Given this list of marker genes RHOB, MAP2K2, EMC1, RMDN3, ANAPC2, DUSP19, RALBP1, CCT8L2, PSMD9, SHISA2, FAM20A, SLC35D1, PPFIBP2, TARS2, KCNH2, NME6 (NME/NM23 nucleoside diphosphate kinase 6), ANAPC16, RPTOR, GPR61, PRAP1, CPQ, CENPH, NRDE2, EIF2B4 (eukaryotic translation initiation factor 2B subunit delta), ETFDH, VDAC3, ELMO3, SREBF2, GFM1, TMEM273 (transmembrane protein 273), AAMDC, RABGAP1L, ARL4A, ARL5B, ZNF7, PLEKHH1, VSIG10L, RTCB, MESD, OAS1, MAP1S, PLG, BORA, MYPN, NCCRP1, PIF1, RCBTB1, CHMP4B, TRIQK, MFSD12, TOPBP1, MSL2, MRPL2, TLL2, RNF40, MMP11, RACK1, FRS2, YTHDF1, DRP2, SEPTIN9, CCT4, STAB1, TXN2, NELFCD, ATP5F1D, CHTF8, RBL1, MRPL36, ERRFI1, DGCR8, CTDNEP1, ALDH1L2, CBX6, RARG, RBMXL2, CLDN7, C22orf23, LAS1L, SWI5, POLR2H, C6orf132, NOB1, BUD31, PDHA2, REEP4, NUP50, TPPP, B9D2, NSUN5, ENTPD6, WBP11, OPN1SW, TRIM29, PGBD5, DRG1, MDC1, PSD, CDKN1A, GLRX5, TOMM7, ZNF175, UBXN11, WDR3, TNIP1, PHACTR4, MAPK1, CERS6, CHPF, OPN1LW, EGR3, ESAM, IL12RB1, IBA57, TAPT1, ARHGEF4, DAPL1, TRIM35, CCDC88B, GCHFR, ZC3H7B, KCNK5, ANKRD54, RXRA (NCBI Gene Id 6256), PCBD2, TRAF2, CPTP, CD109, BOD1, TAF4B (NCBI Gene Id 6875), PSMD12, ANGPTL4, SLC9A5, RPS3, EVPL, SPRED1, GATA1, INTS9, EXOSC1, RNF24, NOL11, PIP5K1B, PPIP5K1, TKFC, ECSIT, CERS5, TRUB1, TANGO6, COPS5, COX19, C11orf87, PLD4, MECR, MFSD2A, SLC6A4, MYO1H, B4GALT4, PEF1, ADH4, MARCO, ZNF483, STAT1, RBM11, CAPN10, SP7, CRYL1, SLC35A4, BCL6B, PPP1R7, TCEAL8, RBBP5, GLOD4, GARIN1B, DHX32, PPM1B, B3GNT7, HJURP, SYNDIG1L, NEUROD2 (neuronal differentiation 2), MIS12, DNAJC24, MRPL46 (NCBI Gene Id 64128), LONP1, SCFD2, PGAM2, GTPBP3, SPMIP5, SRRM1, ZSWIM7, FST, RITA1, NCKAP1L, TRAM2, KLHDC2 (kelch domain containing 2), PSMD8 (NCBI Gene Id 5714), CP, NMT1, ZNG1B, SLC2A10, DCAF12, here is a description of the gene set: Human Gene Set: GSE14308_TH17_VS_INDUCED_TREG_DN from publication Wei G, Wei L, Zhu J, Zang C, Hu-Li J, Yao Z, Cui K, Kanno Y, Roh TY, Watford WT, Schones DE, Peng W, Sun HW, Paul WE, O'Shea JJ, Zhao K (PMID 19144320) studied in species Homo sapiens Multipotential naïve CD4+ T cells differentiate into distinct lineages including T helper 1 (Th1), Th2, Th17, and inducible T regulatory (iTreg) cells. The remarkable diversity of CD4+ T cells begs the question whether the observed changes reflect terminal differentiation with heritable epigenetic modifications or plasticity in T cell responses. We generated genome-wide histone H3 lysine 4 (H3K4) and lysine 27 (H3K27) trimethylation maps in naïve, Th1, Th2, Th17, iTreg, and natural (n)Treg cells. We found that although modifications of signature cytokine genes (Ifng, Il4, and Il17) partially conform to the expectation of lineage commitment, critical transcription factors such as Tbx21 exhibit a broad spectrum of epigenetic states, consistent with our demonstration of T-bet and IFN-gamma induction in nTreg cells. Our data suggest an epigenetic mechanism underlying the specificity and plasticity of effector and regulatory T cells and also provide a framework for understanding complexity of CD4+ T helper cell differentiation. Genes down-regulated in comparison of Th17 cells versus induced regulatory T cell (Treg).